The following is a description of a gene set: Mouse Gene Set: GOBP_NEGATIVE_REGULATION_OF_MACROPHAGE_MIGRATION species: Mus musculus Any process that stops, prevents or reduces the frequency, rate or extent of macrophage migration., and this is the list of marker genes: Cd200, Cd200r1, Mmp28 (matrix metallopeptidase 28 (epilysin)), Mif, Cyp19a1, Hc, Emilin1, Abr, Stap1, Cnn2, Slamf8, Bcr